The following is a description of a gene set: studied in species Mus musculus Mouse Gene Set: REACTOME_DNA_REPLICATION DNA Replication, and this is the list of marker genes: Mcm2, Skp2, Polg, Ubb, Pola1, Prim1, Ube2s, Psmc4, Uba52, Pole, Mcm5, Psmd8, Psmb2, Ccne2, Pole2, Cdc26, Gins4, Ube2c, Ccna2, Fzr1, Rfc1, Lig1, Rfc5, Rbx1, Anapc16, Adrm1, Pold2, Gins1, Rpa3, Rpa1, Cdc23, Pcna, Mcm6, Anapc4, Psmd14, Polrmt, Cdc6, Psma2, Dna2, Orc1, Gmnn, Psmd7, Psma5, Psmd1, Cdt1, Psma1, Psma4, Rfc3, Anapc1, Psmd13, Pole3, Pold4, Gins3, Ccne1, Orc3, Cdk2, Mcm3, Orc6, Rps27a, Anapc5, Pold1, Psmc2, Ube2e1, Anapc11, Psmd11, Psmb7, Mcm4, Psmd6, Psmc6, Orc2, Rpa2, Anapc7, Rfc4, Psma7, Fen1, Mcm8, Kpna1, Rfc2 (replication factor C (activator 1) 2), Psma6 (NCBI Gene Id 26443), Ube2d1, Psma3, Psmb4, Psmd2, Orc4, Orc5, Mcm10, Anapc2, Anapc10, Prim2, Cdc27, Ssbp1, Psmd3 (NCBI Gene Id 52891), Cdc7 (cell division cycle 7), Ccna1, Anapc15, Ubc, Psmc1, Twnk, Gins2, Skp1, Psmd12, Psmb5, Pold3, Psmc5, Kpnb1, Cdc16, Kpna6, Psmb3, Psmb1, Psmc3, Dbf4 (NCBI Gene Id 27214), Pole4, Mcm7, Pola2, Cul1, Polg2, Psmb6, Cdc45, Uba52rt